The following is a description of a gene set: part of: Transcriptional regulation by RUNX2 Reactome Pathway: Regulation of RUNX2 expression and activity Several transcription factors have been implicated in regulation of the RUNX2 gene transcription. Similar to the RUNX1 gene, the RUNX2 gene expression can be regulated from the proximal P2 promoter or the distal P1 promoter.<br>Activated estrogen receptor alpha (ESR1) binds estrogen response elements (EREs) in the P2 promoter and stimulates RUNX2 transcription. Estrogen-related receptor alpha (ERRA) binds EREs or estrogen-related response elements (ERREs) in the P2 promoter of RUNX2. When ERRA is bound to its co-factor PPARG1CA (PGC1A), it stimulates RUNX2 transcription. When bound to its co-factor PPARG1CB (PGC1B), ERRA represses RUNX2 transcription.<br>TWIST1, a basic helix-loop-helix (bHLH) transcription factor, stimulates RUNX2 transcription by binding to the E1-box in the P2 promoter (Yang, Yang et al. 2011). TWIST proteins also interact with the DNA-binding domain of RUNX2 to modulate its activity during skeletogenesis. Schnurri-3 (SHN3) is another protein that interacts with RUNX2 to decrease its availability in the nucleus and therefore its activity. In contrast, RUNX2 and SATB2 interact to enhance the expression of osteoblast-specific genes. Formation of the heterodimer with CBFB (CBF-beta) also enhances the transcriptional activity of RUNX2.<br>Transcription of RUNX2 from the proximal promoter is inhibited by binding of the glucocorticoid receptor (NR3C1) activated by dexamethasone (DEXA) to a glucocorticoid receptor response element (GRE), which is also present in the human promoter.<br>NKX3-2 (BAPX1), required for embryonic development of the axial skeleton, binds the distal (P1) promoter of the RUNX2 gene and inhibits its transcription. RUNX2-P1 transcription is also autoinhibited by RUNX2-P1, which binds to RUNX2 response elements in the P1 promoter of RUNX2. In contrast, binding of RUNX2-P2 to the proximal P2 promoter autoactivates transcription of RUNX2-P2. Binding of a homeodomain transcription factor DLX5, and possibly DLX6, to the RUNX2 P1 promoter stimulates RUNX2 transcription. The homeobox transcription factor MSX2 can bind to DLX5 sites in the promoter of RUNX2 and inhibit transcription of RUNX2-P1.<br>Translocation of RUNX2 protein to the nucleus is inhibited by binding to non-activated STAT1.<br>Several E3 ubiquitin ligases were shown to polyubiquitinate RUNX2, targeting it for proteasome-mediated degradation: STUB1 (CHIP), SMURF1, WWP1, and SKP2. studied in species Homo sapiens, and this is the list of marker genes: SKP2, TWIST1, NKX3-2, GSK3B, PSMB6, CUL1, ADRM1, PSMC1, PSMD13, PSMB2, PSMC4, PSMA5, PPARGC1B, PSMD8, UBA52, UBC, UBB, ESR1, PSMD7, PSMB3, ESRRA (estrogen related receptor alpha), PSMD6, PSMA7, SKP1, PSMD12, PSMA2, PSMC5, DLX6, RUNX2, RBX1, PSMA6, PSMD11, PSMC6, PSMB5, NR3C1, CBFB, BMP2, PSMD2, RPS27A, PSMA3, PSMD3, MSX2, SEM1, SMURF1, PSMB1, PSMB4, PPARGC1A, STUB1, PSMD1 (NCBI Gene Id 5707), HIVEP3, WWP1, DLX5, PSMB7, STAT1, PSMC2, PSMC3, PSMD14, PSMA1, PSMA4